The following is a description of a gene set: Human Gene Set: GOBP_PURINE_RIBONUCLEOTIDE_SALVAGE Any process which produces a purine ribonucleotide from derivatives of it, without de novo synthesis. species: Homo sapiens, and this is the list of marker genes: APRT, ADSL, ADA, AMPD1, HPRT1, AMPD2, ADK, AMPD3, ADSS1